The following is a description of a gene set: studied in species Homo sapiens part of: Assembly Of The HIV Virion Evidence suggests that the RNA molecules used for the synthesis of Gag and Gag-Pro-Pol are not the same molecules that are packaged into virions. Gag proteins do not appear to aggregate around and capture the RNA contained in the polyribosome from which they emerged, but rather bind to and ultimately encapsidate free transcripts elsewhere. During the replication of retroviruses, large numbers of Gag molecules must be generated to serve as precursors to the structural proteins of the virions. Retroviruses have developed a mechanism that permits expression of the Gag protein at high levels relative to the protein sequences encoded in the pro and pol genes, while retaining coregulated expression. This linkage results from the use of the same initiation codon in the same mRNA to express the gag, pro, and pol genes. Translation of this RNA leads occasionally to synthesis of a fusion protein that is usually called the Gag-Pol precursor but is now more appropriately called the Gag-Pro-Pol precursor Reactome Pathway: Synthesis And Processing Of GAG, GAGPOL Polyproteins, and this is the list of marker genes: VPS37C, VPS37B, MVB12B, VPS28, VPS37D, RPS27A, gag, MVB12A, TSG101, VPS37A, UBB, UBC, UBAP1, UBA52, NMT2